Given this list of marker genes OCA2, PALB2, COL14A1, PALLD, CTSC, KANSL1, RAD51, MC1R, COL7A1 (collagen type VII alpha 1 chain), SMAD4, MGMT, BRCA2, SDHC, ALK, NRAS (NCBI Gene Id 4893), ERCC5, COL17A1, TERT, KRAS, GNAQ, POLH, HRAS, PTPN11, RECQL4, SEC23B, WRN, BRIP1, XPC, TP53, ERCC2, PERP, RABL3, BRCA1, ANAPC1, MRE11, KLLN, ERCC6, SDHD, BAP1, TYMS, USF3, SOX5, MDM2, CXCR4, ACD, BRAF, STK11, MITF, RAD51C, SLC6A17, RAD51D, MBTPS2, TRPV3, XPA, SF3B1, AKT1, GNA11, TERF2IP, TYR, MMP1, ERCC4, CDK4, CDKN2A, DDB2, CDKN2B, PIK3CA, NBN, POT1, AAGAB, ERCC3, RNF43, CYSLTR2, RAF1, CHEK2, RAD50, SDHB, PTEN, MBD4, BARD1, ZEB2, here is a description of the gene set: species: Homo sapiens Human Gene Set: HP_MELANOMA The presence of a melanoma, a malignant cancer originating from pigment producing melanocytes. Melanoma can originate from the skin or the pigmented layers of the eye (the uvea). Melanoma